The following is a description of a gene set: species: Mus musculus Mouse Gene Set: GOBP_BASE_EXCISION_REPAIR_AP_SITE_FORMATION The formation of an AP site, a deoxyribose sugar with a missing base, by DNA glycosylase which recognizes an altered base in DNA and catalyzes its hydrolytic removal. This sugar phosphate is the substrate recognized by the AP endonuclease, which cuts the DNA phosphodiester backbone at the 5' side of the altered site to leave a gap which is subsequently repaired., and this is the list of marker genes: Ung, Nthl1, Ogg1, Tdg, Ercc5